The following is a description of a gene set: BBSome-mediated cargo-targeting to cilium Human Gene Set: REACTOME_BBSOME_MEDIATED_CARGO_TARGETING_TO_CILIUM studied in species Homo sapiens, and this is the list of marker genes: RAB3IP, TTC8, CCT5, LZTFL1, ARL6, BBS4, SSTR3, BBS5, BBS9, TCP1, MCHR1, CCT3, CCT4, BBS1, SMO, BBS7, BBIP1, CCT2, MKKS, CCT8, BBS10, BBS12, BBS2